The following is a description of a gene set: Human Gene Set: MIR3119 species: Homo sapiens from publication Chen Y, Wang X (PMID 31504780) Genes predicted to be targets of miRBase v22 microRNA hsa-miR-3119 in miRDB v6.0 with MirTarget v4 prediction scores > 80 (high confidence targets)., and this is the list of marker genes: SGPP1, ETV7, CEPT1, FBXO33, AK3, TSPAN31 (NCBI Gene Id 6302), GCLC, DFFA, OSBPL8, STEEP1, CACNA1I, SHISA6, CYP27C1, LGALSL, STK38L, COL5A1, ZNF559-ZNF177, PLXND1, TBX6, XBP1, CCNQ, CCDC85C, PPDPFL, ROCK1, ITGA1, EIF2B2 (eukaryotic translation initiation factor 2B subunit beta), ERI2, RCOR3, ZMAT1, PAX5, HECTD2, EXTL2, PURA, IQCK, NWD2, CAMKK1, NUP88, PPM1E, ZAR1, FKBP11, HMOX2, ZNF138, PAK5, IER5L, BMAL1, ADCYAP1R1, ZBTB44, MEGF6, MELTF, CGGBP1, ITGAV, CBL, RAB6A, GCH1, ZNF107, SHROOM4, CORIN, PHOSPHO1, ASB14, ZFAND3, BTG2, RAP1B, POLR1F, TSHZ2, ZNF428, RASL11B, LUC7L3, SLC15A5, FASTKD5, TENM4, KLRK1, PTPN11, RUNDC3B, NUMB (NCBI Gene Id 94910), ZNF559, DRD1, METTL8, ZNF385B, C10orf88, FMOD, UBXN10, NOL4, GRIK3, CDCA2, MAN1A1, DNAJC27, TENM3 (NCBI Gene Id 55996), PGGT1B, PDE8B, MFAP5, NAA30, STRBP, AQP4, SIK1, LINC02873, TNKS1BP1, ZIC1, IQCH, TBK1, ARK2C, MEF2A, SCIN, TCF7L2, ADNP, CAAP1, MAPRE2, ATOSB, KATNBL1, KCNAB3 (potassium voltage-gated channel subfamily A regulatory beta subunit 3), BMPR2, EMP2, DGKH, CNGB3, SLC49A4, DCSTAMP, PALS1, MFHAS1, PHF3 (NCBI Gene Id 23469), FRMD4B, KLF4, MOSMO, MXD3, PRPF40A, TLN2, ROCK2 (NCBI Gene Id 9475, Rho associated coiled-coil containing protein kinase 2), SIPA1, CCDC134, MEIG1, PCSK5, HDLBP, PDZRN4, ABHD17C, PPP6C, CD68, NF1, MAPK10, BTAF1, DDX60L, MTDH, METTL9 (NCBI Gene Id 51108), MASP2, ANLN, HYKK, NBEA, TRPC1, ETNK1 (ethanolamine kinase 1), MTCL1, FOXN3, ZNF596, FZD4, PTP4A1, SNRNP40, CD47, HP1BP3, RUNX2, ENTPD1, CD2BP2, PRKAR2B, TNNT2, HIPK1, RELN, ACTC1, BNC2, FAS (NCBI Gene Id 355), RGL1, AMFR, SNX16, GEMIN8, WSCD2, CAP2, ATP10B, CHMP4B, UBE2W, TMEM64, PHACTR2 (NCBI Gene Id 9749), SLC25A5, TNFAIP8L1 (NCBI Gene Id 126282), RNF138, ENTPD7, CEP41, ENTPD4, MARVELD1, C16orf90 (NCBI Gene Id 651035), ARMC8, KLHL8 (NCBI Gene Id 57563), TGM2, ILRUN, ZNF667, CACNA1E, MYO9A, PDE1C, UBE2O, INO80D, WIPF1, BRWD1, RBAK, FZD2, UQCRB, SP3, ZNF518A, GRID2, SORT1, ZNF430, SNX18 (NCBI Gene Id 112574), GRIP1, FNIP1, SON, CALML4, MFSD9, PYGO1, TMX4, MOCS2, PURG, FAM86B1, CDH20, GRIA2 (glutamate ionotropic receptor AMPA type subunit 2), C6orf141, KCNN3, ZNF362 (zinc finger protein 362), IKZF3, HYDIN, AFF1, LEF1, HMGB2, PPP4R3B, SLC25A28, WNT3 (NCBI Gene Id 7473), GRAP2, VLDLR, CEACAM7, ZNF831, RAB14, SLC30A7, RFX3, HOMER1, C6orf120, ZNF143, CYP2R1, ST6GAL2, ZNF131, TEAD1, PRLR, KIAA1549, CASD1, GJC3, BAZ2B, CLEC12A (NCBI Gene Id 160364), PIM2, CLEC2B, UNC13A, CERCAM, DTL, TSEN54, PPTC7, IL31RA, TXNIP, ZNF549, PDE5A, KANSL1L, ATG14, NISCH, SLC24A2, PCSK2, TMEM168, PABPC4, EHD4, NUP153, HSDL2, SETBP1, ACTR3B, SIRT1, HNRNPK, CD58, MAN2A1, VAT1, STX3, LANCL2, WTAP, ENSG00000275993, ANKRD33B, TRAT1, HOXA1 (homeobox A1), SLC26A4, FAM86C1P, SLC4A8, ARHGAP5, CPLX2, JAKMIP2 (janus kinase and microtubule interacting protein 2), PIK3R1, IRF2BP2, CTTNBP2, RAP1GDS1, LRAT, SPCS3, GLRB, SEC62, CMTM3, SLC35G3, ABCA5, NR3C2, IL13RA1, FOXO1, TLX1, NFATC3, PSD3, LNX1, SMIM13, ZNF568, NUCKS1, KIF3B, OGFRL1, ILDR2, CLDN3, CNGA3, ZNF268, PRRX1, BZW2, GNA14, SLITRK5, N4BP2L1, HOXA10, ARMS2, AFDN, GBE1, MFSD6, SYT2 (synaptotagmin 2), WDSUB1, RAB6C, SLC2A6, RRP1B, DENND1B, GRIA3, GORAB, ASIC5, ABCE1, MDH2, JARID2, CARMIL1, NAMPT, IREB2, MTMR12, PTPRT, SNTB2, MOB1B, MYO1C, HDAC9, PICALM (phosphatidylinositol binding clathrin assembly protein), ECHDC3, SLMAP, ZFTA, LIFR, CTNNB1, ZNF274, GDAP1L1, GDI2, UHRF1, ANKRD22, CEACAM6 (CEA cell adhesion molecule 6), ZNF426, NPDC1, ANGPTL2, TREML2, YWHAE (NCBI Gene Id 7531), IL6ST, DYNC2H1, LONRF1, FRMPD4, SCUBE3, GK5, NRXN1, ZNF718, BCAP29, NRF1